Given this list of marker genes FGF2, SULT4A1, KPNA1, ZNF132, ZNF157, IFNA14, RGS7, EXOC4, TACC2, PHOX2B, GLRA3, GNG4, HOXB7, NTNG2, P2RY10, NEB, PART1, GCM1, IL4, NR1I2, PSG1, COLGALT2, PSD, NR3C2, NPAS2, EDIL3 (NCBI Gene Id 10085), F2RL1, ZNF202, LGI1, GJB5, SERPINA4, HTR2C, CDH4, LILRA1, ADAMTS3, SOAT2, SLC15A1, ATP4B, CCL16, LDB3, ELL2, TTTY1, FZD5, SPRR2C, AMMECR1, GRIK1, FGA, KLRC4, TBX19, RORB, HOXC11, HCRTR2, COL8A1, PAX7, PHLDB1, STARD5, MLLT10, SLC6A4, DRD1, MAP2, LECT2, PPM1E, SIX6, TENM4, POLR1HASP, ABO, ST8SIA1, TNK1, KCNA5, FSHR, FOSL1, MAP2K7, RYR3, ROR2, RXRG, CCR3, VIP, ANXA10, KRT34, ERCC4, SLC17A1, AKAP3, OR2B6, SLC6A2, JADE3, PLPPR4, CRHR1 (NCBI Gene Id 1394), PAX6 (paired box 6), SLC17A3, CMKLR2, CADM4, ATXN3, SCN7A, B4GALT6, CAMK4, S100A5, HNF1A, NHEJ1, SLC17A7, ABCB1, TBXT, TRIO, CEP162, CDC73, F2RL3, FGF18, CALN1, SUPT3H, KRT2, ZSCAN26, MINDY2, DNAJC22, STAC, CTRL, ADAM20 (NCBI Gene Id 8748), SRPK3, MPZL1, MAGEA9, IPO9, HTR1E, IL11RA, SLC46A3, GPR19, GYS2, PLXNA3, PCM1, RAD51D, ATF2 (activating transcription factor 2), DMD, MAGEA8, HSD3B2, ADAMTSL3, COL19A1, NPFF, TMEM26, APOBEC1, here is a description of the gene set: Neighborhood of CDH4 cadherin 4, type 1, R-cadherin (retinal) in the MORF expression compendium Human Gene Set: MORF_CDH4 Neighborhood of CDH4 studied in species Homo sapiens